The following is a description of a gene set: Genes positively differentially expressed in cell type: Neutrophil upon treatment with cytokine: IFN-γ in mouse lymph nodes in vivo. Mouse Gene Set: CUI_NEUTROPHIL_IFNG_RESPONSE_UP studied in species Mus musculus from publication Cui A, Huang T, Li S, Ma A, Pérez JL, Sander C, Keskin DB, Wu CJ, Fraenkel E, Hacohen N (PMID 38057668) Cytokines mediate cell-cell communication in the immune system and represent important therapeutic targets. A myriad of studies have highlighted their central role in immune function, yet we lack a global view of the cellular responses of each immune cell type to each cytokine. To address this gap, the authors created the Immune Dictionary, a compendium of single-cell transcriptomic profiles of more than 17 immune cell types in response to each of 86 cytokines (>1,400 cytokine-cell type combinations) in mouse lymph nodes in vivo. A cytokine-centric view of the dictionary revealed that most cytokines induce highly cell-type-specific responses. For example, the inflammatory cytokine interleukin-1β induces distinct gene programmes in almost every cell type. A cell-type-centric view of the dictionary identified more than 66 cytokine-driven cellular polarization states across immune cell types, including previously uncharacterized states such as an interleukin-18-induced polyfunctional natural killer cell state., and this is the list of marker genes: Nampt, Irgm1, Oasl2, Herc6, Cd274, Grina, Ifi47, Gbp5, Slc31a1 (solute carrier family 31, member 1), Gbp7, Socs1, Gbp2, Wfdc17, Ifi204, Rsad2, Igtp, Psmb8, Stat1, Parp14, H2-T23, Psmb9, Isg15, H2-D1, Tnfaip2, Irf1, Samhd1, Casp4, Ifitm3, Fcgr4